The following is a description of a gene set: Genes in the cancer module 500. Human Gene Set: MODULE_500 species: Homo sapiens, and this is the list of marker genes: GPR143, CD247, KRT4, SPP2, GAGE12G, SEMA4D, RABIF (RAB interacting factor), DDX6, IL6, TFF2, P2RY6, IL1RL2, ANKRD26 (ankyrin repeat domain containing 26), ST6GAL1, PLAUR (plasminogen activator, urokinase receptor), ANXA13 (NCBI Gene Id 312), HOXA4, GNRH1, FUT6, RAC2, KLF5, ERCC2, TERF2, EPB41, KCNAB2, ABCE1, KCNMB3, MSH3, NFKB2, NDST2